The following is a description of a gene set: studied in species Homo sapiens Human Gene Set: GOCC_FILAMENTOUS_ACTIN A two-stranded helical polymer of the protein actin., and this is the list of marker genes: MYO1C, JAM3, PDLIM5, PDLIM7, KPTN (NCBI Gene Id 96493), PRICKLE4, MYO6, SPECC1L, APC2, ACTG1, DPYSL3, CD2AP, RAC3, ARPC3, LDB3, DIAPH3, NCKAP1, ESPN, PDLIM2 (NCBI Gene Id 64236), DUSP22, CARMIL1, BLOC1S6, MYO1A, PDLIM3, PDLIM4, MYO3A, PDLIM1, MYO18B, SPECC1